Given this list of marker genes RAF1, ARAF, MAP2K2, JUN, CHRNA4, KRAS, CHRNB4, MAPK1, BRAF, CHRNA3, CHRNA7, NRAS, MYC, BCL2, MAPK3, CHRNB2, FOS, MAP2K1, HRAS, here is a description of the gene set: Human Gene Set: KEGG_MEDICUS_ENV_FACTOR_NNK_NNN_TO_RAS_ERK_SIGNALING_PATHWAY NNK/NNN to RAS-ERK signaling pathway. Pathway ID: N01344. Pathway type: Env factor. Pathway class: nt06210 ERK signaling. studied in species Homo sapiens Pathway Definition from KEGG: (NNK,NNN) -> CHRN -> Ca2+ -> RAS -> RAF -> MEK -> ERK -> (FOS,JUN,MYC,BCL2)